The following is a description of a gene set: Human Gene Set: GOBP_NEGATIVE_REGULATION_OF_ANDROGEN_RECEPTOR_SIGNALING_PATHWAY species: Homo sapiens Any process that decreases the rate, frequency, or extent of the androgen receptor signaling pathway., and this is the list of marker genes: NCOR2, FOXP1, FOXH1, NCOR1, SIRT1, PHB1, TCF21, HEYL, NODAL, HDAC1, ZBTB7A, SMARCA4, PIAS2, SFRP1, TCF7L2, DAB2, IGF1